Given this list of marker genes Gper1, Plek, Plcb3, Plcg1, Scp2, Itpka, Plcg2, Lhcgr, Itpkc, Ipmk, Itpkb, Itpk1, Myh9, Inppl1, Pth, Ip6k3, Cd244a, P2ry1, Nudt11, Adcyap1r1, Ip6k2, Pth1r, Nudt3 (nudix hydrolase 3), Synj2, Grk3, Pou1f1, Plcd1, Galr2, P2ry6, Ippk, Ppip5k1 (diphosphoinositol pentakisphosphate kinase 1), Mas1, Ppip5k2, Pten, Ntsr1, Nudt4 (NCBI Gene Id 71207), Plcb1, Snca, Prkg1, Ptafr, Nudt10, Avpr1b, Ip6k1, here is a description of the gene set: Mouse Gene Set: GOBP_INOSITOL_PHOSPHATE_METABOLIC_PROCESS studied in species Mus musculus The chemical reactions and pathways involving inositol phosphate, 1,2,3,4,5,6-cyclohexanehexol, with one or more phosphate groups attached.